Given this list of marker genes MIRLET7B, SELENOS, MEF2C, IRF7, CCL5, CCR5, CDKN2A, NOD2, GHSR, SIRT1, here is a description of the gene set: studied in species Homo sapiens Any process that modulates the frequency, rate or extent of macrophage apoptotic process. Human Gene Set: GOBP_REGULATION_OF_MACROPHAGE_APOPTOTIC_PROCESS